The following is a description of a gene set: studied in species Mus musculus FGFR1 ligand binding and activation Mouse Gene Set: REACTOME_FGFR1_LIGAND_BINDING_AND_ACTIVATION, and this is the list of marker genes: Fgf6, Fgf2, Fgf10, Fgf8, Fgf20, Fgf3, Fgf1, Fgfr1, Gipc1, Tgfbr3, Fgf23, Kl, Fgf9, Fgf5, Fgf17, Fgf22, Fgf4